Given this list of marker genes Slc16a11, Slc16a3, Slc16a1, Mpc2, Slc16a7, Mpc1, here is a description of the gene set: Mouse Gene Set: GOBP_PYRUVATE_TRANSMEMBRANE_TRANSPORT species: Mus musculus The directed movement of pyruvate across a membrane.